Given this list of marker genes KAT2A, DLST, OGDH, DBT, DLD, OGDHL, BCKDK, ABHD11, KGD4, here is a description of the gene set: Human Gene Set: GOCC_OXOGLUTARATE_DEHYDROGENASE_COMPLEX A multi-enzyme complex that catalyzes the oxidative decarboxylation of alpha-ketoglutarate (also known as 2-oxoglutarate) to form succinyl-CoA. The complex comprises multiple copies of three enzymes referred to as E1, E2 and E3: oxoglutarate dehydrogenase (lipoamide) (E1), dihydrolipoamide S-succinyltransferase (E2) and dihydrolipoamide dehydrogenase (E3). Additional proteins may also be present. species: Homo sapiens